Given this list of marker genes SFXN1, SULT1A1, GSTM3 (NCBI Gene Id 2947), IGFBP3, PDPK1, WIPF1 (WAS/WASL interacting protein family member 1), PDCD4, RASD1, MAP3K8, FTO, ANXA9, ARID4B, GALNT6, NOCT, DLX2, CYP1A1, BZW2, IRX3, CDC14B, MAST4, BCL2, TFPI, MORF4, CTSZ, NFE2L2, PMP22, ABCG2, FHL2, LMCD1, GDPD5, LURAP1L, KCNN4, BYSL, ELOVL5, RRS1, BASP1, SLC7A5, BAMBI, MYO5A (NCBI Gene Id 4644), CD55, MB21D2, B4GALNT1, LACTB (NCBI Gene Id 84943), GEM, SLC2A6, FAT1, THBD, SGCG, here is a description of the gene set: Up-regulated genes in the cancer progenitor (stem) cells corresponding to side population (SP) MCF7 cells (breast cancer) positive for MUC1. Chemotherapy, radiation, and growth inhibitory drugs preferentially eliminate actively growing cancer cells. Cancer recurrence is currently thought to be due to nondividing cancer stem/progenitor cells that are resistant to these therapies. Different therapeutic approaches need to be considered for the elimination of the cancer stem cell population. Immunotherapy is one such approach. In addition to specificity and lack of toxicity, immunotherapy targets cancer cells irrespective of their state of proliferation, as long as they express particular tumor antigens. For that reason, it is important to examine if the tumor antigens that are currently being tested as immunotherapeutic agents are also present on cancer stem cells. This study aimed to determine if one well-known tumor antigen, MUC1, which is being tested as an immunotherapy target on tumor cells, is also expressed on the quiescent cancer stem/progenitor cells. We used the so-called side population (SP) cells found in the MCF7 breast cancer cell line, which we first confirmed by cell surface markers and gene profiling to be highly enriched in cells that fulfill specific functional, phenotypic, and molecular criteria for being tumor stem/progenitor cells. We show that these cells express MUC1 and give rise to MUC1(+) tumors in vivo, which maintain the MUC1(+) SP population. MUC1 on SP cells is hypoglycosylated and heavily sialylated; the characteristics of the tumor-specific form were expressed on mature cancer cells and recognized by tumor-specific T cells and antibodies. This suggests that stem/progenitor cells, like mature tumor cells, would be targets of MUC1-directed immunotherapy. from publication Engelmann K, Shen H, Finn OJ (PMID 18381450) Human Gene Set: ENGELMANN_CANCER_PROGENITORS_UP studied in species Homo sapiens